The following is a description of a gene set: Genes down-regulated in B16 melanoma (day 3): untreated versus mock treatment during adoptive transfer therapy. species: Homo sapiens from publication Kerkar SP, Goldszmid RS, Muranski P, Chinnasamy D, Yu Z, Reger RN, Leonardi AJ, Morgan RA, Wang E, Marincola FM, Trinchieri G, Rosenberg SA, Restifo NP (PMID 22056381) Human Gene Set: GSE29164_UNTREATED_VS_CD8_TCELL_AND_IL12_TREATED_MELANOMA_DAY3_DN Myeloid-derived cells comprising the tumor stroma represent a heterogeneous population of cells critical to the structure, function and growth of established cancers. We have recently found that engineering tumor-specific CD8+ T cells to secrete IL-12 (IL-12TD) can lead to striking improvements in T-cell activity against established melanomas in murine models. Surprisingly, IL-12-dependent enhancement of CD8+ T-cell anti-tumor function did not occur through direct ligation of receptors on lymphocytes or NK cells. Instead, IL-12 sensitized host bone marrow-derived tumor-stromal cells, partly through interferon-gamma, to indirectly enhance the effects of adoptively-transferred T cells. Direct presentation of antigen by tumor was not necessary, but MHC class I expression on endogenous cells was essential for IL-12 mediated anti-tumor enhancements. Upon successful treatment with IL-12TD cells, we observed the selective elimination of tumor-infiltrating CD11b+ F4/80+ macrophages, CD11b+/ClassII+/CD11c+ dendritic cells and CD11b+/Ly6C+/Ly6G- but not CD11b+/Ly6C+/Ly6G+ myeloid-derived suppressor cells within regressing lesions. These results are consistent with a model whereby IL-12 triggers the maturation of myeloid-derived cells into competent antigen cross-presenting cells. Licensed recognition of these antigens by effector T cells may in turn trigger the collapse of the tumor stroma and aid in the regression of large vascularized lesions., and this is the list of marker genes: PDPR, ZBTB42, EXOC2, METRNL, RAB36, TRIM33 (NCBI Gene Id 80027), CDC6, SMCHD1, AP1G2, H3C4, SVIL, TLN1, PPFIA1, RPE, ERBB3, HMGN5, DHX16, RAD18, PRR13, SKIC8, EPS8, CDC42SE1, PRRC2C, AP2A2, RPS14, TUSC1, TSPAN17, BCL2L11, RSPRY1, PRKCD, SPOP, BCL2L2, TDRD7, PPP4R3B, ATF7, SLC26A6, ATAD2B, CELF1, RNF38, SPIDR, ZCCHC8, DGKG, RNF144A, HELLS, RRM1, APAF1, GMFB, S1PR2, NDUFA4, PSMB3, PLK4, LSR, MOB1A, TIMELESS, CMC2, ZNF414, ZNF106, SUN1, SPTAN1, SBK1, ATP6V1A, SH3BP4, TYK2, SGMS1, RFC5, ADSS2, SIRT3, FUT7, FBXO28, UGDH, C1D, PARP8 (poly(ADP-ribose) polymerase family member 8), ATP5PB, NIPSNAP3A, SNRK, NCBP1, TNFAIP8L1, NCEH1, OSBPL3, AGFG1, UPB1, RELCH, REEP5, NUCKS1, GPI, INPP5B, TRAM1, ERCC6L (NCBI Gene Id 54821), PPP1CA, NUF2, GEN1, YWHAQ, RAB29, ARL6IP6, DDX46, RAB3D, STAP1 (signal transducing adaptor family member 1), XPO7, RECQL, CYLD, TMCC1, MPC2, SET, CIPC, STK36, MSH3, PUM3, PWP1, WDR62, OAT, RBL1, STRN (NCBI Gene Id 6801), RGS18 (regulator of G protein signaling 18), PLIN3, PPA1, GLA, IFIT2, SNORD89, ADK, SIRT1, THOC7, NCOA1, PRDX6, HLCS, ATP13A3 (ATPase 13A3), SEPTIN9, MTMR14, TFEC, NPC1, ITGB2, SEMA4A, MTFR1, RHEBL1, UNC119B, PALM, API5, TUBA4A, CCT2, ADAM19, RSRC1, KIF23, ZC3H15, RAP1A, TNRC18, PILRB, DEPDC1, KBTBD11, L1CAM, KATNBL1 (NCBI Gene Id 91186), MCM4, RAMAC, FBXO3, MIS18A, SGPP1, TNRC6B, FANCL, WDR26, CYP4F3, LRRC8C, TAF2, ATP10A, SIDT2, MFAP1, SPC24, TTF1, OGDH, PDIK1L, RNASEH1, CEP55, HMGB2, SMC3, IFNAR1, PTGR1, WASHC5, GNAI3, ANKH (NCBI Gene Id 7995), TESK2, PXMP2, GPLD1, VAMP1, PRKAB2, VPS13B, CDK7, RAF1, SOCS4, ITGA1, UBE3B, INTS5, NOA1, ARPC1B, PPIH, WDR11, MAP2K6, POLA1, OGT, PANK3, ARL14EP, ZNF229, WDR3, FLOT2